Given this list of marker genes GID4, MS4A5, CRISP2, PRM1, ODF1, TPTE, PPP1R2C, TUBA3C, IQCE, HSPA1L, ODF2, SLC6A16 (solute carrier family 6 member 16), REXO5, GAPDHS, OAZ3, DNALI1, PLAAT1, ACTL7A, SPACA9, APH1B, GSG1, YBX2, PIAS2, TEX14, KDM4D, FNDC11, ZPBP, RIBC2, SPATA6, TCP11 (t-complex 11), CABYR, PHF7, SPAG6, GRK4, KCNK4, TNP1, ANKRD7, ZC2HC1C, TKTL1, PRM2, IL13RA2, MLF1, CLPB, CCNA1, FSCN3, LDHC, ACTL7B, GSTM3, MROH7, SPA17, UBQLN3, PGK2, DDX25, ACSBG2, SOX5, TSSK2, ZMYND10, ROPN1, ACRV1, CCIN, RFPL3S, AKAP3, CCDC70, PDHA2, RBMXL2, ACR, TCFL5, here is a description of the gene set: Human Gene Set: GNF2_CCNA1 Neighborhood of CCNA1 Neighborhood of CCNA1 cyclin A1 in the GNF2 expression compendium studied in species Homo sapiens